The following is a description of a gene set: Mouse Gene Set: GOCC_RECYCLING_ENDOSOME_MEMBRANE The lipid bilayer surrounding a recycling endosome. studied in species Mus musculus, and this is the list of marker genes: Slc9a9 (solute carrier family 9 (sodium/hydrogen exchanger), member 9), Ldlr, Pacsin2, Rab12, Snx18, Rab13, Atp13a4, Cftr, Rab11fip3, Clip3, Cmtm6, Syt11, Slc39a4, Aqp2, Scamp3, Rap2a, Plekhb2, Insr, Clcn4, Abhd17c, Rab8a, Mtmr4, Slc1a1 (solute carrier family 1 (neuronal/epithelial high affinity glutamate transporter, system Xag), member 1), Pigr, Ndrg1, Fzd7, Rap2b, Acap1, Slc30a10, Slc31a2, Stx6, Gria1, Scamp5, Atp11c, Inpp4a, Rab11fip2, Bok, Vti1b, Mcoln2, Lamp5, Slc36a2, Baiap3, Scamp2, Tpcn1, Ehd3, Pdlim4 (NCBI Gene Id 54412), Neu3, Rab11a, Rab17, Slc11a2 (NCBI Gene Id 18174), Dync1li1, Micall1 (NCBI Gene Id 27595), Zfyve27 (NCBI Gene Id 72352), Rab11fip4, Rab11b, Rac1, Atg9a, Clcn3, Gga3, Rab11fip5, Abcb11, Nsg1, Cd274, Entrep1, Slc26a7 (solute carrier family 26, member 7, NCBI Gene Id 208890), Stx12, Slc9a6, Rab10, Rab4a, Abhd17a, Slc31a1, Atp9a, Slc9a5, Abhd17b, Ehd4, Sorl1, Syt5, Ehd1, Vps13b, Rffl, Slc9a7, Arf6, Atp11b (NCBI Gene Id 76295), Tfrc, Ehd2, Scamp4, Sorcs2, Slc9a3, Atg9b, Washc1, Lztr1, Zdhhc2, Rap2c, Vamp3, Scamp1, Atp13a3, Gripap1, Ntrk1, Slc9b2